Given this list of marker genes OTX2, LETM1, COL4A1, PPP2R5D (NCBI Gene Id 5528), BANF1, MBTPS2, FKRP, KIAA0586 (KIAA0586), NSD1, MAPK1, POMGNT1, STIL, FANCI, FGFR2, LRRC32, MITF, ARNT2, NSD2, MED25, DISP1, SMG8, POMGNT2 (NCBI Gene Id 84892), MAPKAPK5, PTDSS1, ROBO1, DAG1, PPP1R21, RAP1B, PPP1R12A, FGFR1, CRIPTO, KRAS, FOXH1, CSGALNACT1, NFIX, CSPP1 (centrosome and spindle pole associated protein 1), CRPPA, GPR161, KIF7, FKTN, STAG2, ESAM (NCBI Gene Id 90952), CPLX1, CNOT1, TUBB2B, SHH, PROP1, RXYLT1, ALG12, COL18A1, DHCR24, PLCH1, CDC42BPB, CILK1, PAFAH1B1, SIX3, WNT3, RBM8A (RNA binding motif protein 8A), L1CAM, HESX1, ZSWIM6, RSPO2, FOXA2, FGFRL1, NODAL, LARGE1, EZH2, B3GALNT2, NKX2-1, SSR4, POMK, PTCH1, POMT1, RAB5IF, HYLS1, EHMT1 (euchromatic histone lysine methyltransferase 1), TAF1, PLAA, PROKR2, SOX2, COX7B, FGF8, RNF125, ZIC2, HCCS, NDUFB11 (NADH:ubiquinone oxidoreductase subunit B11), DYNC1I2, GAS1, RRAGC, DLL1, CTBP1, GLI2, TBX4, MUSK, IDH1, PACS1, RNU4-2, LHX4, PCGF2, WDR11, PIK3CA, B4GAT1, PIEZO2, POMT2, TGIF1, EBF3, STT3A (NCBI Gene Id 8071), POU1F1, POLR1A, SOX3, PIGA, CDON, APC2, here is a description of the gene set: Abnormal septum pellucidum morphology Human Gene Set: HP_ABNORMAL_SEPTUM_PELLUCIDUM_MORPHOLOGY An abnormality of the septum pellucidum, which is a thin, triangular, vertical membrane separating the lateral ventricles of the brain. studied in species Homo sapiens